Given this list of marker genes RAB8B, ECRG4, APLN, GHRL, UCN, CRHBP, CRH, here is a description of the gene set: Human Gene Set: GOBP_REGULATION_OF_CORTICOTROPIN_SECRETION studied in species Homo sapiens Any process that modulates the frequency, rate or extent of the regulated release of corticotropic hormone from a cell.